Given this list of marker genes LPGAT1, LCLAT1, AGPAT5, MBOAT7, PLA2G4D, PLA2G4E, here is a description of the gene set: Human Gene Set: GOBP_PHOSPHATIDYLINOSITOL_ACYL_CHAIN_REMODELING Remodeling the acyl chains of phosphatidylinositol, through sequential deacylation and re-acylation reactions, to generate phosphatidylinositol containing different types of fatty acid acyl chains. species: Homo sapiens